The following is a description of a gene set: species: Homo sapiens Human Gene Set: HP_INFANTILE_SPASMS Infantile spasms represent a subset of \epileptic spasms\. Infantile Spasms are epileptic spasms starting in the first year of life (infancy). Infantile spasms, and this is the list of marker genes: ERMARD, DMXL2, NAXD, AFG2A, ST3GAL3, ARFGEF1, PHACTR1, CDC40, GNAO1, GLUL (NCBI Gene Id 2752), ACTL6B, TSEN34, BTD, SLC1A4, MT-TK, CUL3, PIGP, SUCLA2 (NCBI Gene Id 8803), RNF13, MT-TV, FBXL4, DHX16, ADGRG1, ACBD6, CASK, DHX37, TUBA1A (tubulin alpha 1a), KCNQ5 (NCBI Gene Id 56479), GNAQ, ASAH1, MT-TL1, CDK19, NGLY1, ATP6V1A, SPTBN1, AFG2B, CDKL5, GNB1, D2HGDH, CNPY3, TUBB2B, IFNG, DOCK7, TSC1, WDR45, ATP6V0C, PLCB1, MT-ND5 (mitochondrially encoded NADH:ubiquinone oxidoreductase core subunit 5), CHD3, KDM4B, ATP2B1, PIGQ, UFSP2, KCNH5, TSEN54, EEF1A2, NACC1, GCDH, GABRG2, TSC2, NEXMIF, PPIL1, GCSH, CTNNA2, NTNG1, SLC25A10, FBLN1, MT-ND6, TSEN2, PDHA1, UBA5, STAMBP, MT-ND2, MT-ATP6, SRPX2 (NCBI Gene Id 27286), KCNA1, ZNHIT3, PTPN23, SLC19A3, GABRB3, HCFC1, MT-ND3, HDAC4, GRM7, CDH2, TRPM3, TANGO2, PNKP, TRIM8, GUF1, NPRL2, HK1, DCX, STXBP1, POLR1A, NDUFAF8, SCN2A (sodium voltage-gated channel alpha subunit 2), CLCN4, SCN1B, PAFAH1B1, SMC1A, CEP85L, PRRT2, CAPRIN1, TUBG1, UFC1, KCNB1, GABBR2 (NCBI Gene Id 9568), MMACHC, EIF4A2, GRIN2B, MT-ND1, TUBB3, ERCC5, NEDD4L, MECP2 (NCBI Gene Id 8274), CRELD1, CNTNAP2, TUBA8, MT-TW, GRIN1, MT-ND4, DEPDC5, GOLGA2 (golgin A2), TSEN15, PIGA, SPTAN1, RUSC2, PI4KA, VPS53, OTUD7A, ALG14, ARX, NTRK2, DOLK, DNM1, MGAT2, ATAD1, SEPSECS (Sep (O-phosphoserine) tRNA:Sec (selenocysteine) tRNA synthase), SLC32A1 (NCBI Gene Id 140679), TUBB2A, ALG2, FBXO28, SLC25A22, MAPK1, HIBCH, PCDH12, NEUROD2, RALGAPA1, SLC35A2, DPAGT1, APC2, STRADA, NPRL3, MACF1, SIK1, LONP1, ALG13